The following is a description of a gene set: species: Mus musculus Mouse Gene Set: GOBP_POSITIVE_REGULATION_OF_RELEASE_OF_CYTOCHROME_C_FROM_MITOCHONDRIA Any process that increases the rate, frequency or extent of release of cytochrome c from mitochondria, the process in which cytochrome c is enabled to move from the mitochondrial intermembrane space into the cytosol, which is an early step in apoptosis and leads to caspase activation., and this is the list of marker genes: Wdr35, Pdcd5-ps, Hrk, Bbc3, Dnm1l, Bnip3, Mmp9, Pla2g6, Bcl2l11, Pdcd5 (NCBI Gene Id 98188), Fam162a, Fas, Tnfsf10, Bmf, Bid, Bik, Mllt11, Pmaip1, Gper1, Mff, Plaur, Pycard, Trp53, Moap1, Pink1 (NCBI Gene Id 68943), Bax, Bak1, Bad